The following is a description of a gene set: Human Gene Set: HP_ESOPHORIA A form of strabismus with both eyes turned inward to a relatively mild degree, usually defined as less than 10 prism diopters. Esophoria species: Homo sapiens, and this is the list of marker genes: MECR, TBX1, HOXB1, SCN8A, KIDINS220